Given this list of marker genes NOP53, NDUFA5, RPA3, PFAS, MGA, PSMG2, KIF15, EP400, PTMS, MAPK11, PCID2 (NCBI Gene Id 55795), OGFOD1, C6orf120, CHD1L, PLA2G4A, THRAP3, ZC3H14, P2RX5, ODC1, ZNF195, METAP2, ATP13A1 (ATPase 13A1), MTHFD1, RPS17P5, LRRC42, HEG1, RPS27L, PTGES3, DDX51, DIXDC1, RXYLT1, DMXL1, SNRPA1, DNAJC16, ANXA2P2, NUP155, BACH2, PTTG1, ACOT7, RPS27, HMGN1, CEP112, NELFCD, PAQR4 (progestin and adipoQ receptor family member 4), EED, RCL1, ANP32B, HES2, ATP8A1, TUBB6, DIPK1A, GPN1, CSE1L, RPL5, GSTM2, ERI3, CRYZ, ZZZ3, MAP3K4, ATF1, BCAT2, PES1, ARMCX2, EIF6, TMEM39B, TIMM8B, NSD2, EIF3F, HSPA9, PSMA4, SNRNP27, VGLL4, PSMB2, MRPL4, FTO, SUPT3H, STAMBPL1, MGST2, CD200, USP16, KIF5C, TTC33 (NCBI Gene Id 23548), MRPL40 (mitochondrial ribosomal protein L40), OCLN, HDAC2, RBBP8, NUCKS1 (nuclear casein kinase and cyclin dependent kinase substrate 1), HDHD3, ABCD3, POLR1G, MT2A, OR7E36P, PPIE, KDELR2, CSTPP1, ESPL1, AMIGO2, BRCA1, PIP5K1B, KIF22, PUS7, USP12, GNE, DST, LPIN1, ESYT1, LMAN1, RPL32, CCNC, USP22, SIRPG, NDUFC2, TSKU, CKS2, PASK, POLR3E, MDC1, MAZ, TPP2, ENO3, SNRPF, UPF3A, COL16A1, PPP3CC, CDYL, MBD3, COQ7, RTCA, NUDT21, SUPV3L1 (Suv3 like RNA helicase), CHMP6, MYH1, REXO2, PXMP2, EIF2B5, TMEM131, GSTZ1, SRSF6, NUSAP1, CLEC2D, APPL1, GTF3A, POLE3, HEXA, MORC2, TMEM208, DDX39B, RCAN1, METTL18, MMD, RFX7, PTER, CENPI, GRSF1, CDKL3, SLAMF1, RCN1, MYC, HOMER2 (NCBI Gene Id 9455), OTUB2, PCNT, NAA38 (NCBI Gene Id 84316), MEAK7, AP2B1, RARS1, DPY19L1, NDUFB8, UTP18, MPDU1, HSPB8, UQCRC2, BANF1, BFAR, ADRM1, NFS1, HNRNPA2B1, PPIP5K1, LYRM2, TCEA1 (transcription elongation factor A1), PPOX, SYNGR3, PSMA2, ABCF2, AGGF1, VARS1, EMC6, NOC3L, OSBPL3, CENPF, CTNNBL1 (NCBI Gene Id 63927), RANGAP1, DNAAF2, CUL2, BIRC3, SLC35D1, RPL4, LACTB2, CIZ1, here is a description of the gene set: Human Gene Set: GSE3982_NEUTROPHIL_VS_TH2_DN Genes down-regulated in comparison of neutrophils versus Th2 cells. from publication Jeffrey KL, Brummer T, Rolph MS, Liu SM, Callejas NA, Grumont RJ, Gillieron C, Mackay F, Grey S, Camps M, Rommel C, Gerondakis SD, Mackay CR (PMID 16474395) In the present study we used Affymetrix oligonucleotide microarrays to produce gene transcription profiles for the major leukocyte types in humans. This comprehensive dataset enabled us to not only establish which genes were expressed in each leukocyte type, but also which genes were expressed in each subset after activation. The used of a comprehensive dataset of gene profiles from all the major human leukocyte subsets enabled a novel and powerful means for identification of genes associated with single leukocyte subsets, or different immune paradigms. studied in species Homo sapiens